Given this list of marker genes Inpp4b, Zfp811, Klhl41, Lipt2, Sema4g, Ttn, Arhgap6, Erlin1, Gsdmc2, Fank1, Gsdmc, Cps1, Ms4a1, Ncl, Sema6a, Slc17a5, Thrb, Gsdmc3, Eaf1, Prss3b, Zmat4, Adnp, Setdb1, Zbtb37, Nrsn1, Smad4, D2hgdh, Nme8, Ptprj, Trarg1, Rgs20, Mmp20, Arhgap27, Ebf3, B230219D22Rik, 0610030E20Rik, Sspn, Nubpl, Enpep, Hs3st1, Chgb, Caly, Fmr1, Ttc9, Gsdmc4, Ahctf1, Spryd7, Tfdp1, Stil, Ndst2, Wdr33, Erc1, Lpin3, Dclre1c (NCBI Gene Id 319261), Pgm5, Zbtb33, Dtd2, Prg4, 1700017N19Rik, Atp2a3, Cngb1, Dact1, Cttnbp2nl, Cdk6, Gimap1, here is a description of the gene set: from publication Chen Y, Wang X (PMID 31504780) studied in species Mus musculus Mouse Gene Set: MIR_12200_3P Genes predicted to be targets of miRBase v22 microRNA mmu_miR_12200_3p in miRDB v6.0 with MirTarget v4 prediction scores > 80 (high confidence targets).